The following is a description of a gene set: Human Gene Set: HP_AORTIC_ARCH_ANEURYSM Aortic arch aneurysm An abnormal localized widening (dilatation) of the aortic arch. studied in species Homo sapiens, and this is the list of marker genes: KCNH1, GTF2IRD1, VPS37D, RFC2, CASZ1, PDPN, LOX, DNAJC30, CHD7, UBE4B, BAZ1B, FKBP6, HSPG2, SEMA3E, ACTA2, THBS2, EIF4H, GTF2I, NOTCH1 (NCBI Gene Id 54781), GATA5, SKI, GTF2IRD2, TMEM270, MMP23B, GABRD, KCNAB2 (NCBI Gene Id 8514), NKX2-5 (NK2 homeobox 5), PRKCZ, LUZP1 (NCBI Gene Id 7798), TBL2, RERE, SMAD6, SPEN, BUD23, CLIP2, STX1A, LIMK1, ELN, NCF1, METTL27, PRDM16, TGFBR2